Given this list of marker genes SACM1L, OSBPL5, C2CD2L (NCBI Gene Id 9854), ESYT3, STIMATE, GRAMD1A, GRAMD1B, BLTP2, ESYT2, SARAF, BLTP1, GRAMD1C, here is a description of the gene set: species: Homo sapiens A contact site between the endoplasmic reticulum membrane and the plasma membrane, structured by bridging complexes. Human Gene Set: GOCC_ENDOPLASMIC_RETICULUM_PLASMA_MEMBRANE_CONTACT_SITE